Given this list of marker genes IHH, MED25, MED12 (NCBI Gene Id 9968), PTRH2, BMPR1B, CANT1, TGDS, FOXP2, ERI1, KNSTRN, BMP2, OPA3, IFT140, CSGALNACT1, GDF5, HOXA13, PIK3CD, CHSY1, HNRNPR, ANKRD11, FLNA, here is a description of the gene set: Displacement of the 2nd finger from its normal position. Deviation of the 2nd finger Human Gene Set: HP_DEVIATION_OF_THE_2ND_FINGER studied in species Homo sapiens